Given this list of marker genes MFF, NFE4, UGT1A4, SUPT5H, KCNK3, TKT, AMBP, SLC30A8, H2AC11, PDXK (pyridoxal kinase), SDCBP, H4C2, KCNB2, MAP3K21, CPOX, TAF11L11, ENDOG, ZBTB38, P2RY1, NOLC1, THAP12, KNSTRN, IRAK2, ID2, TAF11, TPST2, MSH6, ATOH1, BHLHE40, IL12A, MYF5, PIK3R2, H2AB1, NEUROG2, GSTZ1, E2F4, H3C14, POLR1D, PDSS1, CARD9, SDS, PAFAH1B3, SMC3, DPYD, GBP4, NPC1L1, NPAS3, CAMK2D, TARS2, MYOG (NCBI Gene Id 4656), BARD1, H2AC12, H3C11, CHMP1A, SNX2, LILRB2, KHK, TLR9, H2BC9, MICU1, SHMT1, CCDC88C, H3Y1, MYO9B, VWA1, PCYT1A, DR1, TPM2, GSTM1, H2AZ1, MYOM3, GYG1, NOG, HES4, H2BC10, SCARB2, ATF4, AOC3, XDH, TREX1, GABBR2, XBP1, OLIG2, BMAL1, ACTN4, MAP3K13, NEUROG1, ADRA2C, AGXT, H3-7, HEY1, KIF20B, GOLGA5, GRHL1, KYAT1, DCLRE1B, FLRT3, BCL2, TM4SF19, NQO2, SEPTIN12, FXR2, PRKRA, HIF3A, ECT2, PPP3CB (protein phosphatase 3 catalytic subunit beta), ARNT, H2AX, TAF6L, S100A6, BHLHA9, KCNK5, SYT5, BMP6, ABCG1, S100A5, CENPA, CHRAC1, KCNB1 (potassium voltage-gated channel subfamily B member 1), IMPA1, PDGFC, ELAVL1, ENG, LRP6 (LDL receptor related protein 6), CDSN, CNOT9, TAF12, MESP1, APPL2, ST6GAL1, S100P, BNIP3L, RBPMS, NRBP1, ANO2, FBXW11, CUBN, MEF2B, CER1, BLM, H4C13, BHLHE23, ZBED6, ATOH7, LCT, F11R, S100A16, NARS1, HOOK1, NTRK2, H2AC6, PKM, KARS1, PGRMC1, TCFL5, H4C5, AIMP1, TAF11L8, IKZF3, E2F3, C16orf89, POLR2J2, RAP1GAP, RNF8, POLE4, VAPB, CREB3, IKBKG, KLHL7, MLXIPL, SARS1, ZDHHC3, CADM1, PITX2, POLE3, XPNPEP3, TPCN1, CHUK, TAF11L6, H4C1, SP100, STARD3, SPPL2A, TAF13, FBXO7, PON1, KCNK16, CARS1, ASCL3, CANT1 (calcium activated nucleotidase 1), TRNT1, UGT1A1, TUBA1A, PGLYRP4, KYAT3, BMAL2, HSP90AA1, GADD45A, PRPS2, ID1, SRGAP2C, CAMK2A, ENO1, HHEX, TBX18, GDF15, ST3GAL2, LDB1, TPI1, RALGAPA2, TLR6, TAF11L13, NHLH1, RILP, H4C3, ERBB2, SIM2, FECH, ERP29, DARS2, ACHE, VEGFA, BHLHE22, TAF11L10, SLC7A9, H4C8, ATF2, ERCC5, UCP2, USF2, WARS1, METTL3, NCOA3, RAB11FIP2, ABCB9, ASMT, GSTM4, NTRK1, RELA, PAXX, NCOA2, SOD1, PECAM1, ARNT2, GBP5, ANO4, ERBB3, SOS1, TARBP2, PPP2R1A, CRYL1, H2BC8, TAL1, MIGA2, ANG, IZUMO1, POLR2J3, CITED1, MYCL, FOXP2, H4C9, ACSL6, H3-4, KCNK9, CCL5, ADRB3, H2AC15, ABCG2, PIP4K2B, ATOH8 (atonal bHLH transcription factor 8), MAPK6, THAP1, UPB1, NR0B1, EFEMP2, S100A11, H2BN1, EIF2AK1, KRT1 (keratin 1), TIMM9, THBS1, MACROH2A2, CYBA, PHB2, CARNMT1, SERPINF2, NEUROD4, DAXX, PDK2, CENPF, NAALADL1, TYRP1, CLCN1, NFYB, HPD, H2BC13, CEBPA, SLC25A14, H2BC6, FGFR2, GRM6, MAP3K12, CIB2, H4C11, KCNN4, RDH5, SMCHD1, SEPHS1, DSG3, JDP2, GIMAP7, NACC2, TFEB (NCBI Gene Id 7942), CR2, H2AB2, GRHPR, ERBB4, PRPS1L1, JAML, H2AZ2, H2AC17, H3-3A, DRAP1, NFYC, DNTTIP1, RAB11FIP3, USF3, CDADC1, BORCS8-MEF2B, NOD1, HMOX1 (heme oxygenase 1), SRGAP2, ST13, FUT9, EEA1, MYF6, GLCE, NR2C1, TAF11L2, TAL2, LSM5, CCDC103, KCNH2, CSF1, FZD9, NPM1, FAP (NCBI Gene Id 2191), ASCL1, ATIC, GBP1, NRF1, HES2, PDCD10, TPM1, GTF2A2, DCK, GZMA, GPD1L, MMUT, MACROH2A1, DEFA5, NFE2L1, S100B, SLC51B, H2BC21, GSTA4, STAT1, TCF4, B2M, POLR2J, ACADL, RALGAPA1, CCDC66, H3C1, ATP1B2, MSTN, PANK1, SOS2, ADORA1, H2AC18, TYR, CYP2R1, SIM1, TRIM8, TAF11L3, ADD2, ANO1, ZMYM1, SDCBP2, CAV1, RNF40, YWHAE, IRAK1, HSPB8, MME, H2AP, ZNF397, UGT1A9, MMAA, H2AC13, GEN1, WDR54, ZBTB7B, MIGA1, ZHX1, LYL1 (NCBI Gene Id 4066), HES6, IL17F, TRIM5, SMC1A, ENPP1, VAPA, SLC3A1, H2AC8, HES5, CRYAB, TYW5, RASIP1, ITGA3, GPHA2, MITF, ADD1, SYNDIG1, CENPS, TMEM192, PRMT2, MEIOSIN, GSTM2, TCF12, LRP4, CEP57, PSPH, NR2F2, STING1, HIP1, ASCL5, UBA3, HLA-G, GNPTG, SIRT6, CDA, STOM, FLT4, HVCN1, MSH3, DROSHA, ADAM10, PHB1, ZNF318, STK26, HEY2, MVD, GID8, CEACAM1, ZHX2, NR4A3, WWTR1, ADRA1B, SOHLH1 (spermatogenesis and oogenesis specific basic helix-loop-helix 1), TWIST2, H2BC1, TBC1D22A, H3C13 (H3 clustered histone 13), BNIP3, MLX, UGT1A3, FIGLA, ZHX3, PADI2, RRAGA, BLTP3B, NDP, CYBB, IL10, PIP4K2A, KATNA1, E2F2, HELT, ZNF396, MEF2C, RABL3, KATNB1, KCNN2, STARD3NL, AIFM1, MAG, MEF2A, BANF1, RCHY1, RPE, GRPEL1, MZF1, ABCG5 (ATP binding cassette subfamily G member 5), TFAP4, ADRB2, AMELX, ADRA1A, OLIG1, SLC26A5, MSI1, STAT3, SLC4A1, GLIPR2, SREBF2, PPP3CA, TPD52L1, NADK2, DNM1, KYNU, MSH2, TAF6, GDNF, TENM3, MYCN, H4C15, COL9A1, SLC5A5, MASP1, RUVBL2, HMGCS1, NEUROG3, SETMAR, BCL11A (BCL11 transcription factor A), PEX11A (peroxisomal biogenesis factor 11 alpha), PTPA (protein phosphatase 2 phosphatase activator), ATP1B1, SCX, TAF11L14, SNF8, PRPS1 (NCBI Gene Id 8254), FOXP3, VPS25, PDGFA, MYC, RILPL1, TCF24, MESP2, SLC51A (NCBI Gene Id 200931), H3C8, H2BC17, ZDHHC2, MKLN1, SSBP1, FXR1, H3C15, CRPPA, NR4A1, H2AC1, TAF11L7, ASMTL, CENPW, KCNK17, H2AC25, SUPT4H1, RBM11, NPR3, H3C6, SUPT3H, TERF1, H2BC14, BIRC5, KLRF2, NUDT16L1, SP1, IRF3 (NCBI Gene Id 3661), RAG1, ST13P4, IKBKB, CEP43, NUDT21 (nudix hydrolase 21), TAF11L4, GABBR1, PSMD7, COMMD1, ERN1, CAMK2B, TSSK4, MAX, CHRNA7, IL12B, AOX1, MMACHC, AGTR1, NPAS2, NEUROD2, HTN3, EXD2, ACOD1, CFHR5, BDKRB2, H2AC21, SLC4A11, EPRS1, ACOT7, EPAS1, LYRM4, PDE2A, RALGAPB, RRAGD, HPS1, STK10, H2AC4, CHKA, SLC33A1, UGT1A7, INHBB, RBM44, AMHR2, PARK7, PYCARD, POLR2C, CASQ2, ABCB10, PSAP, PHETA1, TRPC6, NPAS1, MTMR1, PAFAH1B2, LPL, DEFA3, SNX9, H3C7, COL9A2, SLC11A1, ARMCX5-GPRASP2, ACTN1, GLB1, BST2, TYMP, PON2, XPA, CCDC88A, GSTM3, OXA1L, E2F5, FBXO4, ZBED4, ANO6, MTTP, ATP2A1, PDSS2, IRAK3, PEX11B, CHMP4A, SLC39A13, TAF4, NR0B2, ADCY8, NECTIN1, TREX2 (NCBI Gene Id 11219), MTUS2, ANO7, CENPT, PLD6, TFE3, ALDH3A2, ZBTB1, LILRB1 (NCBI Gene Id 23445), CLU, DEFA4, ACOX1, CEACAM8, HOGA1 (4-hydroxy-2-oxoglutarate aldolase 1), HES3, TBX15, H4C14, TAP1, SOX6, MGAT4A, RRM2, PDGFRA, IDH1, ADRA2A, CADM3, RUNX1, NECTIN3, QTRT2, SFPQ, ALS2, EXT1, PPCS, HIF1AN, ABTB2, TPPP, HES7, ISCU, SRI, AURKA, AOC1, ANO3, GHR, MXD3, ATF3, TPD52, APOE, TMEM132A, BTRC, H2AC7, CHMP4C, LRRFIP1, MEF2D, H3C10, PDLIM4, ATG7, CRYM, H2BC12, UBA5, GSS, PRMT5, MSC, APOA4, CEACAM6, UGT1A10, NPAS4, MICU2, CLOCK, MYH9, CALCOCO2, DNPH1, FBLN5, VPS4B, TRIM9, H2BK1, S100Z, KCNK12, IL17D, CEACAM5, CLPX, SLK, GREM1, MFSD1, ADA2, RTN4, PDCD6, CLTRN, H2AL3, PEF1, COL9A3, STK4, DDIT3, MUC13, S100A1, RRAGC, GTF2A1, LRRK2, IZUMO3 (NCBI Gene Id 406876), NEUROD1, RIPK1, MYOD1, MLXIP (NCBI Gene Id 728551), NEUROD6, GALE (NCBI Gene Id 2582), SREBF1, ABTB3, SMAD3, MAP3K10, CREB3L3, SNRPC, NFS1, PAPSS1, GPHB5, YWHAH, PON3, MXI1, DNM1L, GBP2, APOA2, H4C16, XCL1 (X-C motif chemokine ligand 1), FERD3L, H2AC19, MICU3, HEXA, CBY1, KCNK13, MAP3K11 (NCBI Gene Id 4296), CPQ, NCOA1, DPP4, ACVR1, MAD2L1, PPP2CA, AXIN1, STK25, TAF8, NAA60, PANK3, GBP3, HM13, PTPRT, FICD, ADRB1, MTPAP, RAB11FIP4, TENM1, ZBTB16, PIK3R1, ALDH1A3, TYROBP, ASCL2 (NCBI Gene Id 430), H2BC19P, ATF6, MID2, SPPL3, CST7, FMR1, PRTFDC1, EXT2, TTN, TFAP2B, MXD1, SRR, PRMT8, NAE1, TUBB2B, SUPV3L1, MGAT2, CISD1, DEFA6, ABCD2, GCH1, TPST1, STAT5B, USF1, TXNRD2, TERT, DUSP29, CD247, CASR, DAB2IP, SYT10 (synaptotagmin 10), UXS1, NR4A2, CHEK2, H2BW1, HIP1R, KCNK1, H2AC20, ANO5, ATP1A2, SRM (spermidine synthase), PDGFB, TENM4, ATP1A1, TXN, S100A13, GGCT, H2BC4, CISD2, FZD4, SNX1, HNF1B, TAF3, H2BC5, EPHX2, SLC3A2, NOS2, RACK1, TGFB2, H3C2 (NCBI Gene Id 8358), GLA, MAP3K5, INPP5F, NECTIN2, HIF1A, H2BC18, PARP1, NSMCE3, SPPL2B, TLR4, H3Y2, CEP131, CAT, GLUD1, CORO1A, E2F1, TCF23, NLRC4, ABCG4, PLN, MXD4, H2AB3, TPD52L2, SOHLH2, PTPRO, SYT6, AKT1, H4C12, PLEK, S100A10, ROM1, HPGDS, JCHAIN, ZBED1, BHLHE41 (basic helix-loop-helix family member e41), GUCY2D, TPM4, PKD2, HAND1, VIL1, H2BC15, NKX2-5, CIP2A, FIBIN, IL17A, PSMF1, THRSP, H2BC7, KMT2A, TOX3, H4C7, H3C3, AHR, E2F6, HSD17B4, MECOM, TFEC, SYNE1, MCL1, HNF4A, OLIG3, IMPA2, STC2, CIDEA, DSCAML1, CBS (NCBI Gene Id 875), RBPMS2, PTGS2, H3C12, TBX1, GARS1, CD300H, TAF7, SLC25A27, HSD17B1, GRPEL2, PDCD6IP, CSF1R, HESX1, NUDT16, SH3GLB1, MNT, TCF21, NAGA, ABCG8, ZNF174, TFRC, RCC1, PHETA2, H3-5, TRIM37, HAND2, STRA8, KCNK2 (NCBI Gene Id 3776), H2BC3, H2AJ, POLR1C, AHRR, SRF, SYT1, UGT1A6, TOP2A, PAFAH1B1, PNPO, PTF1A, SMIM1, ACP3, NLGN4X, EPM2A, JAM3, SNX6, ASCL4, STUB1, ABCB7, TCOF1, BOK, PEX7, BLOC1S6, H2BC11, TNNC1, ZBTB4, RABEP1 (rabaptin, RAB GTPase binding effector protein 1), TPR, H3C4, MGA, NHLH2, GLDC, UGT1A8, H2BC12L, RIPK2 (receptor interacting serine/threonine kinase 2), TP53, PRPH2, MAP3K9, CAV2, BHLHA15, CD4 (CD4 molecule), POU3F3 (POU class 3 homeobox 3), TAF9B, CAMK2G (calcium/calmodulin dependent protein kinase II gamma), H2BW2, JUP, HES1, QTRT1, SLC7A8, MTHFD1L, H4C4, P4HB, APP, IDE, TRMT112, FCER1G, H2BC26 (H2B clustered histone 26), SLC8B1, TAF4B, TAF11L12, XPNPEP1, ADIPOQ, UGT1A5, G6PD, HEYL, YARS2, H2AC16, BUD23, DGAT2, DGKD, HSP90AB1, TSG101, PTH1R, CEBPB, ECE1, BAK1, MORC2, MGLL, MIXL1, IL6R, HSD11B1, AADAT (NCBI Gene Id 51166), SUPT7L, GCA, ODC1, ANO9, RILPL2, RAN, ID3, CLEC2A, HSPB1, SAE1, BMPR1A, CACYBP, TAF1, ST13P5, PRDM9, DPY30, TWIST1 (twist family bHLH transcription factor 1), KRT10, MAPK4, ENSG00000274276, TMEM266, CARD8, PML, KIT, UBA2, ZNF862, TENM2, DGCR8 (NCBI Gene Id 66034), DIAPH3, FGFR1, TSC2, ROPN1B, STK19, PDXP, TCF15, DAPK3, GALM, MTCL1, APPL1, HPS4, H4C6 (H4 clustered histone 6), HSF1, FLNA, MSGN1, ZNF365, SLC7A13, COQ9, TAF9, EXD1, GPRASP3, DST, ITPR1 (NCBI Gene Id 619543), SPPL2C, ABCD3, NUDT5, SMAD4, WRN (NCBI Gene Id 7486), TP53I3, MID1, SLIT2, HSPB6, NSMCE1, TERF2, APOA1, ACOX2, TIMM10, ID4, TAF11L9, TMIGD1, MYOM1, HARS1, CHMP4B, COL2A1 (collagen type II alpha 1 chain), TCF3, GPD1, KRT25, ABCD1, H3-3B, CEP135, NR6A1, LHPP, SCLY, CGAS, PGLYRP3, TP53BP2, GRM7, CCL11, LSM6, TESC, BAX, ITGB1, HNF1A, CLN6, here is a description of the gene set: studied in species Homo sapiens Human Gene Set: GOMF_PROTEIN_DIMERIZATION_ACTIVITY The formation of a protein dimer, a macromolecular structure consists of two noncovalently associated identical or nonidentical subunits.